The following is a description of a gene set: from publication Yevshin I, Sharipov R, Kolmykov S, Kondrakhin Y, Kolpakov F (PMID 30445619) species: Mus musculus Mouse Gene Set: NRD1_TARGET_GENES Genes containing one or more binding sites for (Nrd1) in their promoter regions (TSS -1000,+100 bp) as identified by GTRD version 20.06 ChIP-seq harmonization., and this is the list of marker genes: Slc25a30, Pradc1, Ier5, Apol7d, H1f2, H2ac25, H2ac20 (H2A clustered histone 20), H2bc13, Dctn4, Kin, 9430015G10Rik, Myc, Clasp1, Ube2f, Lpar6, Ufsp1, Alyref2, Rhbdd3, Helq, Tnpo2, Ubc, H4c14 (H4 clustered histone 14), Brix1, Tuba1a, Zfp866, Arl6ip6, Rpl13a, Pdcl, Aaas, Eaf1, Taf13, Luc7l3, Fn1, Pik3r3, H4c12 (H4 clustered histone 12), Ewsr1, 1810024B03Rik, Orc2, U2af2, Snrpc, Ubtf, Ier2, Zfp646, Hspa8, Arid1a, Rpf1, Emg1, Map2k2, Mrpl44, Hells, Zfp408 (NCBI Gene Id 381410), Med1, Emc4 (NCBI Gene Id 68032), Tmem126a, Mad2l1bp, Vps52, Ndufb10, Rad1, Ppm1b, Dnajc24, Rps18, Slc1a5, Gm15834, Jpt1, H2bc4, Ddit4, Slc3a2, Ecd, Cdk5rap1, Klf6, H2bc18, Stamos, Pheta1 (NCBI Gene Id 231717), Myg1, Frmd8os, 2310058D17Rik, Cdc42se1, Mir8114, Ndrg1, Nip7, Tmem230, Snhg5, Hmox1, Plec, Ywhaz, Actb, Scarna2, Sgsm2, Dohh, Mettl6, Taco1, Calm3, Snord12, Klf10, Rps4x, Nop56, Junos (jun proto-oncogene, opposite strand, NCBI Gene Id 230451), Hnrnph1, Dtl, Zbtb38, Tor1aip2, Ints7, Zfp560, Snrpd1, Ncl, Mtrfr, Tk1, Mfsd13b, Hspa5, Acp2, Stam, H4c9, 2900093K20Rik, Sgk1, 1110020A21Rik, Nfkb1, Fzd1 (NCBI Gene Id 14362), Sh3bp4, Eif1, Srp19, Rgs3, Stx16, Gm13783, Mpp1, H3f3b, Surf2, Mttp, 1700028E10Rik, Prrc2c, Mir1938, Rps29, Scand1, Slc9a1, Ndufaf3, Cyb561a3 (cytochrome b561 family, member A3), Rps21, Bola1, 4632415L05Rik, Tmem208, Alkbh3, Gm26205, Eif3j1, Pelo, Tefm, Kbtbd4, Slc25a5, H2bc12, Snhg8, Wdfy1, Chmp2a, Mettl21a, Spindoc, 2810408I11Rik, Ppp1r8, Mpnd, Trip6, Glul, Dnttip2, Snora24, Ndufb7, Xrn2, Dusp5, Snora73a, Snrnp200, Adamts1, Foxp4, Schip1, Rps26, Rcl1, Sugct (NCBI Gene Id 97907), Dapk3, Brd2, Baiap2, Maoa, Mrps18c, Zfc3h1, Osgin1, Dis3l, Fzd8, Tpm1, Sertad2, Smim8, Ints6, Dhx38, Polr2m, Snord60, Calm1, Pitpnb, 1810013D15Rik, Ubb, Lmna, Rrp15, H4c6, AA474408, Snhg3, BC005537, Ppp1r15a, Arpc5l, H2ac13, Cebpz, Calr, Junb, Luc7l, Uba1, Nsa2, Rhob, Srsf5, Tmem138, Dmap1, Psmg3, Snhg15, Thoc6, S100a4, Rps14, Mir199a-2, Bccip, Surf1, Reno1, Ccnc, Neat1, Pls3, Mrpl12, Pggt1b, Mir423, Mfsd10, Fbxw11, Rpl12 (ribosomal protein L12), H2bc15, Nr1h3, Rpl6, Zfp87, Sdhd, Hnrnpk (NCBI Gene Id 15387), Rpl22l1, Gm12279, Slc38a2, Vim, Cnot10, Dnm3os, Slx4, Ccnt1, Vgll4, H4c2, Ptma, Mkx, H3c7, Cd68, Rbm34, Ccdc25, Taf6l, Rtf2, H2bc11, Srsf2, Ppih, Pabpc1, Dcdc5, Phb2, Gm19569, Spg11, Tcim, Rcc1, Ifrd1, Herpud1, Gapdh (NCBI Gene Id 407972), Arhgap4, Atf1, Rnf185, Gm16062, Zfand3, Rsrc2, Uqcc4, Srsf7, Exosc4, Dhx33, Rab26os, Sp3, Pex6, H3c6, Ppp4r3a (NCBI Gene Id 68734), Rnd1, Suz12, Plau, Nop10, Jmjd1c, Slc35c2, Tdrd3, Wdr89, Cited2, Gm26224, Atp13a1, Mrpl30, Cdr2, H2az1, Ywhag, H2bc8, Thada, Pdcd2, Tsacc, Cd44, 8430429K09Rik, Ttc9c, Mitd1 (MIT, microtubule interacting and transport, domain containing 1), Atf3, Uqcrb, Aar2, Ajuba, Dnajb4, H3c14, Paxip1, Ccz1, Lfng, Anxa1, Taf5, Fbxl12os, Hsp90ab1, Hars1, Tnfrsf12a, Slbp, Ccnyl1, Hilpda, Mrpl53, Ankrd13c, Clcn6, Ppm1d, Atp5f1c, Mir191, Klhdc4, Ftl1, C130036L24Rik (RIKEN cDNA C130036L24 gene), Rps7, Fastkd5, Cox7a2, H3c2, Ppia, Hapstr1, Amd1, Rpf2 (NCBI Gene Id 67239), Rmi1, Mir345, Btf3l4, Ptgs2os, Sec22b, Ubn1, Naa10, H2ac4, Thap2, Lrrc75aos2, Polr2a, Snora9, Ddx18, Cfl1, Afmid, Gm7008, Rsrp1, AA914427, H2ac5-ps, Srpk2, Zscan26, Rdm1, C920006O11Rik, Gm23201, Nfia, Ccl2, H4c4, Mpst, Gm16046, Rexo4, 3110040N11Rik, Scrn3, Gm4189, H1f3, Snx12, Kmt2e, Mfsd11, Ccnd2, Hes1, Fam149b, Tmx1, Rps19bp1, Ints6l, Smtn, Tnrc6c, AI480526, Cwc15, Gas5, Zbtb37, Yeats4, Retreg3, H2ac8, Ccar2, Cage1, Ppp1r11, Utp3, Txndc12, Trib1, Mthfr, Midn, Psmb7, Gm23143, Atg10, Hnrnpc, Tsr1, Nedd9, Cenpo, Tmpo, Wdr74, Ighmbp2, Malat1, Csf1, Txnrd1, Mbtps1, H3c1, Trp53rkb (transformation related protein 53 regulating kinase B), Gpatch3, Rpl3, Taf6 (NCBI Gene Id 21343), Bcl6, Tmem65, Cmc2, H2bc26, Txnl4b, Thap7, Snord43, Rpl36a, Plk2, 4833445I07Rik, Chordc1, Mrpl52, Snhg17, Plpp3, Gm11767, Klhl20, 4930539J05Rik (NCBI Gene Id 75227), Lgals1, Id1 (inhibitor of DNA binding 1, HLH protein), Dclre1b, Hnrnpul2, S100a6 (S100 calcium binding protein A6 (calcyclin)), Ccdc142os, Mbnl2, Tagln2, H2bc3, Hoxc6, Ncaph, Gm13986, Sri, Clk1, Pcbp1, Rbm15 (RNA binding motif protein 15), Phf14, Ttc39d, Tob2, Armc9, Mat2a, Washc2, Slc2a1, Elp3, Rpl41, Mrpl3, Gfm2, Zfp143, Irf2bp2, B2m, Uros, Oser1, Ercc3, Mrpl21, Slc25a29, 1810012K16Rik, Cstf2t, Ier3, Rnf111, Cth, Ube2d3, Serpine1, Rpl7, Syvn1, Med6, Cog8, Eapp, Cir1, Flcn, Prdx1, 1700122E12Rik, Lbh, Airn, Ubox5, Utp14a, Csde1, Col1a1, Ndufaf1, A430105J06Rik, Asb6, H2ax, Tbx3, Plekha4, Fos, Gm15417, Nabp1, Aggf1, Ndufaf7, Cutc, Trub2, Camk2d, Tsc22d1, Ramacl, Kntc1, Camk1, Gm22489, Traf7, Zbtb6, Cdk1, Cct6a, Calm2, Sf3a2, Lrsam1, Tcea1, Mapk1, Tuba1b, Rpl23a, Rpl29, Zc3h10, Ap4b1, Mtbp, Tti2, Mcm3ap, Mir5122, Gm17501, Ptbp1, Krr1, Kdm4a, H2ac15, Pgrmc1, Btg1, Gadd45b, Zfp668, Zbtb7b, Gadd45g, Pomp (NCBI Gene Id 66537), Abtb2, Rpl7l1, Slc25a15, Taf12, Cct3, Rny1, Mplkip, Dcp1a, Ppid, Trim17, Rrp36, Gm43403, Rnpc3, Cnbd2, Rack1, Hnrnpa1, Ric8b, Vps25, Nfe2l2, Txn1, Sf3a3 (splicing factor 3a, subunit 3), Cenpn, Naa16, Timm8b, Ccdc9b, Trim11, Ghitm, H3c8 (H3 clustered histone 8), Tst, Rpl8, 4933437G19Rik, Chpf2, Snord13, Dnajb14, Snord42b, 1600020E01Rik, Ptgs2, Tubb4b, Rps15, Zfp7, Ddit3, Nsun4, Prpf40a, Fbxl9, Cdc7, Antkmt, Phgdh, 5031425E22Rik, Arhgap1, Psph, Tex14, Bms1, Ddx56 (NCBI Gene Id 68057), Exosc10, Fdft1, Idh3b, H3c11, Hars2, Zbtb24, Gm25296, Cbx5, Btg2, Etv3, Strada, Poldip3, BC006965, Cdk10 (cyclin dependent kinase 10), H2bc21 (NCBI Gene Id 99855), Rcan3, Sdc4, H4c11, Mmp14, Ndufs3, Stub1, Setd1b, Gin1, Lrrc1, H2ac11, Jun, Gm22357, Mir125b-1, Gm10459, Mrpl1, E030042O20Rik, Coq4, Rrm2b, Cnpy4, Aqr, Col1a2, Ctdsp2, Gm32950, Mrpl13, Mir100hg, Pigt, Kctd5, Rnd3, Eif4a2, Nsrp1, Trp53rka, Npm1, Snrpe, Mir3091, Kdm4d, Dusp6, Eif4a1, Sox9, 2810405F17Rik